The following is a description of a gene set: Human Gene Set: REACTOME_SIGNALING_BY_WNT studied in species Homo sapiens Signaling by WNT, and this is the list of marker genes: WNT10A, AXIN1, CTNNBIP1, PSMD7, PPP2R5B, H2BC12, CSNK2A2, SOX3, MOV10, RNF146 (ring finger protein 146), H2BC14, AGO1, DVL1, LGR4, LRP6, WNT5A, H2BC11, WNT1, PPP2CB, PRKCG, ROR2, SFRP2, FZD3, H2AC18 (H2A clustered histone 18), PPP3CA, ITPR2, SCRIB, ITPR3, WNT2, LGR5, YWHAZ, AP2B1, H2AB1, AP2A2, VANGL2, SRY, H2AC19, H2AC6, TLE2, SKP1, CLTC, AP2S1, PSMD1, H4C4 (NCBI Gene Id 8360), NFATC1 (NCBI Gene Id 4772), SOST, H3-4, PSMD3, SNX3, FZD4, KREMEN1, ITPR1, GNGT2, HDAC1, UBC, KAT5, H4C3, SOX6, PPP2CA, AP2A1, H2AC4, FZD5, PPP2R5D, AGO4, WNT5B (NCBI Gene Id 84728, Wnt family member 5B), SOX7, PFN1, H4C9, VPS26A, DVL2, PSMC3, H4C13, H2BC3, H2AC14, H3C2, CSNK1A1, H4C14, TNKS, ASH2L, XPO1, H4C8, GNB5, H3C4, PSMD2, H3C15, CBY1, SOX13, PSMD12, WNT4, PPP2R1A, NLK, TNRC6C, TCF7L1, SOX2, ROR1, PARD6A, CAMK2A, PPP3R1, TLE4, GNG5, TRRAP, AKT1, H2BC8, GNG7 (G protein subunit gamma 7), PPP2R5E, H3-3B, RNF43, H4C11 (NCBI Gene Id 8363), KLHL12, FRAT1, CLTA, H2BC26, CUL3, BTRC, AP2M1, MEN1, H2BC5, DKK2, H3C8, H2BC9, SMURF1, H2BC21, RUVBL1, WIF1, CTBP2, PSMA2, GNG13, PSMC5, EP300, H3C1, VPS29, GNB3, H2AZ2, WNT7B, LRP5, HECW1 (HECT, C2 and WW domain containing E3 ubiquitin protein ligase 1), PDE6A, H2BC7, PSMA7, PSMB2, MYC, GNG4, PYGO2, TCF4, LEF1, RUNX3, PSMD11, BCL9L, WNT8B, RSPO1, PSMB7, RBBP5, H3C10, DKK4, PPP2R5C, PSMA3, PRKG1, H2BC12L, H2AC20, PIP5K1B, PSMB6, FZD8 (frizzled class receptor 8), WNT11 (Wnt family member 11), PORCN, XIAP, UBA52, CSNK2A1, PSMA1, RBX1, PLCB3, H4C15, WNT10B, FZD1, CAV1, RSPO3, CTBP1, CSNK2B, DVL3, GNGT1, WNT9B, RHOA, TCF7, GSK3B, H4C2 (H4 clustered histone 2), FZD2, GNAT2, FRAT2, PLCB2, KMT2D (lysine methyltransferase 2D), TERT, H4C1, AGO3, RAC1, SEM1, KREMEN2, H4C16, ZNRF3, H2BC13, PSMA4, CXXC4, CLTB, SOX4, AKT2, H2AC8, LGR6, UBB, PSMA5, H3-3A, PPP2R5A (protein phosphatase 2 regulatory subunit B'alpha), USP8, CSNK1G2, H3C6, H3C13, RAC3, PSMC4, PPP2R1B, TNKS2, H3C14, H3C7, ARRB2, SOX9, PSMD6, PYGO1, H2BC10, TLE3, LEO1, PLCB1, VPS35, PRKG2, WNT6, WLS (Wnt ligand secretion mediator), GNB1, FZD6, WNT16, WNT2B, WNT3A, PDE6G, PRICKLE1, ADRM1, SFRP1, AMER1, H2BC15, GNB2, CTNNB1, CUL1, CCDC88C, RSPO2, RYK, H2BC4, TNRC6B, BCL9, H2AX, PPP3CB, PSMB5, GNG8, PRKCB, GNG2, GNAO1, TMED5, H4C12, H3C3, PSMD8, PRKCA, CSNK1E, H2BC17, TLE5, GNG10, AXIN2, DACT1, PDE6B, H2AC7, GNG3, WNT8A, PSMD14, H3C11, H2AJ, PSMD13, PSMC2, FZD7, WNT7A, CHD8, TLE1 (NCBI Gene Id 7088), AGO2, USP34, H4C5, PSMC1, SMARCA4, KRAS, DKK1, RSPO4, DAAM1, APC, CDC73, H2BC1, SOX17, PSMC6, PSMB3, H3C12, GNG12, GNG11, PSMB1, PSMA6, GNB4, PSMB4, CALM1, TNRC6A, TCF7L2, WNT3, RPS27A, MAP3K7, H2BC6, SMURF2, RAC2, ZRANB1 (NCBI Gene Id 54764), CREBBP, WNT9A, H4C6